Given this list of marker genes EPB41L5, DOCK5, RAC1, ROR2, CDH13, LCN2, MDK, XCL1, EPHB2, CCL26, MIR1908, EPHA4, SEMA4C (NCBI Gene Id 54910), TBC1D24, NFE2L2, ASCL2 (achaete-scute family bHLH transcription factor 2), PLPP3, DDRGK1, CEACAM6, APELA, PIK3CB, SRC, DDR2, CALR, DSCAM, SCG2, HSPA5, FLT1, XBP1, VIL1, ONECUT1, EPB41L4B, CD151, MSTN, PLA2G7, SYNE2, ATP8A1, ITGAX, MYOC, MIR10B, TACR3, MIR10A, RAC2, TEK, SPHK1, GCNT2, CCR1, SEMA4B, SUCNR1, EDN3, SEMA3C, GRN, PFN1, WNK1, EGF, ITGA4, MIR519D (NCBI Gene Id 574480), OXSR1, IL12A, CXCR3, NTN1 (netrin 1), ANGPTL3, DEFB131A, SEMA6A, ELP6, SASH1, IGFBP5, PIK3R1, SELENOK, FGF18, CFAP20, ARHGEF2, NUMB, SERPINB3, CCL25, ACTN4, AZU1, FAM83H, SEMA6C, ITGA6, CLASP1, CXCL16, S100A7, CEMIP, MIR181B1, TGFB1, VTN, GATA3, SEMA3E, KDR, SWAP70, TRPV4, PRKCA, FAM89B, C1QBP, ITGB1, SYNPO2, CARMIL1, TNFSF18, RNASE10, MIR143, HIF1A, BMP4, CAVIN1, MMP2, MIR448, AIF1, HTN1, FLT4, MIR21 (microRNA 21), CXCL8 (C-X-C motif chemokine ligand 8), UBE2I, IL4, ADAM10, ANO6, CCL24, TIAM1, SEMA4A, DAPK3, ABL1, SIRT1, SEMA5B, CLDN3, ELP5, CLDN4, SOD2, MIR200A, MMP9, LPAR1, PDGFB, CREB3, SLAMF1, CCL15, MMP7, MIR711, FUT1, PDCD6, FZD4, EDN2, PDCD10, RIN2, ANXA3, SEMA3A, HRAS, PTK2, PDPN (NCBI Gene Id 29912), BCL2, SELP (selectin P), GPSM3, ARF6, FERMT1, MIR208A, CD74, MIR27B, ITGA3, TACR1, F2RL1, STX3, RELN, SLIT2, RHOC, MIR150, NIPBL, DEFB1, SLC26A5, S100A11, AMOT, SELE, CCR7, ACVR1, MIR487B, HDAC9, HAS2, RTN4, PECAM1, PPM1F, ABL2, CARMIL2, KIF20B, ACTA2, PAK1, AQP1, MIR182, PERP, GREM1, JAM3, MAP4K4, S1PR1, ARHGEF39, BAG4, ITGAV, RIPOR1, MIR135B, ADAM17, HMOX1, CLEC7A, ATP5F1B, CGA, PLCG1, SEMA6D (NCBI Gene Id 80031), CMKLR1, PRKD2, CXCL13, MIR31, IGF1, TNFAIP6, ANGPT4, PLK2, ENPP2, SEMA6B, FGF1, XCL2, TACR2, MIR27A, TERT, AAMP, FGR, TNFRSF14, FAM110C, SPAG9, PTGS2, SEMA4D, RAB11A, PINK1, CCL5 (NCBI Gene Id 8147), STX4, P2RY12, BCAS3, MOSPD2, MAPRE2, ITGA2, CEP43, PRKCE, TNF, KITLG, RARRES2, AGO2, LGALS9, ZC3H12A, DUOXA2, AKT2, CASP8, MIR29B1, SMOC2, CAPN7, PRKD1, WNT7A (Wnt family member 7A), SMAD3 (SMAD family member 3), MIA3, SPARC, IL16, CCL2, CCL21, GRIA1, MIR499A, LYVE1, RHOJ, BCL6, ITGB3, PIK3C2A, CXCL10, TMEM102, ZNF268, GPLD1, TRIP6, NCKAP1L, FOXO4, VEGFB, CCL8, CXCR4, PLAU, EZH2, FER, SHTN1, ACTG1, HDAC6, PDGFRB, PTK2B, MADCAM1 (mucosal vascular addressin cell adhesion molecule 1), THY1, TGFBR1, SERPINE1, PLVAP, CCL23, MDM2, TAC4, MIR302C, GPNMB, IL1B, FERMT3, GLI1, FAT1, HDAC7, SPN, TAC1 (tachykinin precursor 1), CCL1, TNFRSF18, FBLN1, HGF, MIR181D, HSPA8, LEF1, PTPRC, GAB1, P2RX4, JCAD, PLCG2, EPHA1, CCL20, DOCK7, IQCF1, CASS4, AGT, HBEGF, CD47, ITGA2B, INSR, CCL7 (NCBI Gene Id 6354), FGF16, WNT5B, CTTN, SEMA3D, RUFY3, BMP2, NOTCH1, ADAMTS1, MIR146A, NEDD9, DOCK8, WNT5A, MAP3K7, AKAP12 (A-kinase anchoring protein 12), CCDC25, CCN4, NTRK3, BMPR2, CCL18, TGFBR3, CCL4, GLIPR2 (NCBI Gene Id 64148), FN1, GNAI2, CTSH, STAT5A, C1QTNF8, CORO1A, CCAR1, STK39, SEMA7A, CLASP2, RET, PTN, SPI1, MIR296, RRAS2, CXCL12, S100A14, IGSF8, APC, CSF1R, DUOX2, MIR126, AKT1, SCARB1, RAB25, ETS1, MCAM, ADAM9, CFL1, LYN, VEGFA, MIEN1, IL1R1, PIK3CG, SNAI2, CCL3, PROX1, DUOX1, ARTN, BCAR1, ZNF609, IL34, CRKL, JUN, NR4A3, MCU, CD99L2, IL6R, TALAM1, ITGB1BP1, CASR, WDR62, TGFBR2, NRP2, TPBG, DAAM2, PLET1, MALAT1, MET, FSHB, FGF10, MIR30A, ZNF580, MAPK14, PDPK1, CX3CL1, SRPX2, TIRAP, CD99, AKT3, RHOA, SP1, APP, ACVR1B, FERMT2, F2R, AKIRIN1, PODXL, ELP3, PGF, PPP3CA, FGFBP1, SRGAP2C, CBLL1, LGALS3, TRADD, NTF3, CCL14, ICAM1, LAMB1, NRP1, SNAI1, SUN2, GPER1, MEGF8, NSMF, TMSB15C, WASHC1, ANGPT1, FLNA, MIR145 (NCBI Gene Id 406937), MIR451A, F3, FGF2, VSIR, FUT7, TMSB15B, CAMK1D, RICTOR, MAPK1, VPS35, DOCK4, ROCK2, FBXO5, SPOCK2, ARHGEF7, CRIPTO, THBS4, VEGFD, GPI, FGF9, CFAP69, MIR376C, CCL22, GATA2, ITGA5, FPR2, ATM, MIR210, MIR151A, CX3CR1, P4HB (NCBI Gene Id 94756), ARHGAP5, DAB2IP, EGFR, SMURF2, TREM2 (triggering receptor expressed on myeloid cells 2), PDGFC, PREX1, JAK2, MIR199A1 (microRNA 199a-1), CCL19, IL6, MIR222, MAZ, ATP5F1A, MIR132, F10, TNFSF14, PGAM4, DNM1L, MIR590, IRGC, DMTN, LBP, MAP2K1, RRAS, CCL3L3, MYADM, TJP1, PTPRJ, CAV1, FOXC2, SEMA4F, VEGFC, SMO, SEMA3F (semaphorin 3F), FADD, LGMN, RREB1, SDCBP, PIK3CD, JAM2, CD40, FGFR1, MIR939, MMP14, NUS1, CCR2, MIR221, FOXP1, MAP2K2, INSL3, CSF2, SH3RF2, SEMA3B, CXCL17, RDX, CCN1, MTOR, IFNG, GRB7, MYO1C, TRIM32, CCL16, DAB2, ONECUT2, CCL11, PTP4A1, ZNF703, MYCNOS, INSM1, F7, MIR342, EMC10 (ER membrane protein complex subunit 10), TLR4, TAC3, KIT, ANXA1, TMEM201, STAT3, SPRY2, INS, LRRC15, SEMA4G, IQSEC1, HSPB1, ACKR3, PYCARD, DOCK1, EDN1, MAP2K3, BMP7, PDGFD, THBS1, PLG, SMIM22, RHOD, PRDM14, XG, IGF1R, MIR181A2, CSF1, CCL13, TWIST2, CDH5, GFUS, MIR26A1, POSTN (periostin), CRK, TMSB4X, LAMC2, ZP3, ADAM7, SEMA3G, ADAM8, FOXF1 (forkhead box F1), BSG, IRS2, FGF7, SYDE1, DRD1, EPHA2, SSH1, MIR101-1, CIB1, MIR1290, SEMA5A, RIPOR2, LGR6, CCR6, BVES, MIR23A, STK4 (serine/threonine kinase 4), NOS3, PLAA, CLDN1, C5AR1, TWIST1, C3AR1, PHPT1, CDC42, MED23, TCAF2, CCBE1, GAS6, MYLK, PIK3R3 (phosphoinositide-3-kinase regulatory subunit 3), MAPK3 (NCBI Gene Id 5595), DAPK2, ATOH8, ZNF304, FAM107A, FUT4, COL1A1, DEFB124 (defensin beta 124), CCL4L2, MIRLET7F1 (microRNA let-7f-1), BDKRB1, RHOB, AGER, MGAT5, IL23A, TGFB2, HMGB1, ADGRA2, MIR29A, PDGFRA, ADRA2A, CPNE3, PDGFA, MIR20A, SOX9, RAPGEF2, RACK1, here is a description of the gene set: Human Gene Set: GOBP_POSITIVE_REGULATION_OF_LOCOMOTION species: Homo sapiens Any process that activates or increases the frequency, rate or extent of locomotion of a cell or organism.